The following is a description of a gene set: Human Gene Set: GOBP_POSITIVE_REGULATION_OF_MACROPHAGE_DIFFERENTIATION Any process that activates or increases the frequency, rate or extent of macrophage differentiation. studied in species Homo sapiens, and this is the list of marker genes: PF4, FADD (Fas associated via death domain), CALCA, PRKCA, ID2, TGFB1, RB1, CSF1, TRIB1, HSF1, HCLS1, CASP8, RIPK1, LIF, MIR145, IL34